The following is a description of a gene set: Genes upregulated in subsets of cells of a given type within various tumors Human Gene Set: GAVISH_3CA_MALIGNANT_METAPROGRAM_39_METAL_RESPONSE In this study, an extensive analysis was conducted to define meta-programs (MPs) capturing intra-tumor heterogeneity across a spectrum of tumor types. The approach utilized non-negative matrix factorization (NMF) to analyze each cell type separately within individual tumor samples. This involved the analysis of malignant cells, macrophages, fibroblasts, endothelial cells, epithelial cells, T-cells, and B-cells. NMF was executed with varying parameter values (K=4, 5, 6, 7, 8, 9), thereby generating 39 programs for each cell type per sample. Each NMF program was summarized by the top genes based on NMF coefficients.\nRobust MPs were then delineated for each cell type using a set of stringent criteria, including recurrence within the same tumor, similarity to programs in other tumors, and non-redundancy within a tumor. Subsequently, these robust NMF programs were clustered (per cell type) based on Jaccard similarity, leading to the identification of MPs associated with each cell type.\nTo enhance the quality of the MPs, a refinement steps were undertaken, involving the removal of MPs suspected of reflecting low-quality data (with an overrepresentation of ribosomal proteins or mitochondrial-encoded genes), single-study inclusion, or similarity to miss-annotated cell types. species: Homo sapiens from publication Gavish A, Tyler M, Greenwald AC, Hoefflin R, Simkin D, Tschernichovsky R, Galili Darnell N, Somech E, Barbolin C, Antman T, Kovarsky D, Barrett T, Gonzalez Castro LN, Halder D, Chanoch-Myers R, Laffy J, Mints M, Wider A, Tal R, Spitzer A, Hara T, Raitses-Gurevich M, Stossel C, Golan T, Tirosh A, Suvà ML, Puram SV, Tirosh I (PMID 37258682), and this is the list of marker genes: DDIT4, CEBPB, NPTX2, CKB, VCAM1, S100A6, TSC22D3, IER2, ID1, RSL24D1, STC1, TUBA1A, FKBP5, SNHG7, SOX4, CP, IGFBP5, PLP2, ANXA1, LOX, LGALS1, MMP7, SMIM3, FSTL3, MT1A, DEPP1, EPB41L4A-AS1, MT1E, KLF4, MT1M, TGFBI, TMEM91, PMP22, VCAN (versican), MT1F, ID4, GLUL, C1S, EMP3, TMEM45A, NOL3, MT3, CAV1, C1R, C5orf46, EDN1, ZBTB16, MT2A, BGN, MT1X